The following is a description of a gene set: Abnormal liver parenchyma morphology A structural anomaly of the liver located predominantly in the hepatocytes as opposed to stromal cells. studied in species Homo sapiens Human Gene Set: HP_ABNORMAL_LIVER_PARENCHYMA_MORPHOLOGY, and this is the list of marker genes: NPHP3, FOCAD, SLC25A13, CTNS, HLA-DRB1, PTRH2, JAK1, LIPA, BMPER, VPS33B, ESAM, PMM2, BTNL2